Given this list of marker genes PRDM1, TP53, here is a description of the gene set: Transcription of the TP53 (p53) gene is negatively regulated by the TP53 transcriptional target PRDM1 (BLIMP1), which binds to the promoter region of TP53 and probably induces repressive methylation.<p>TP53 functions as a homotetramer. part of: Regulation of TP53 Expression and Degradation studied in species Homo sapiens Reactome Pathway: Regulation of TP53 Expression